The following is a description of a gene set: Absence of melanin pigment in various areas, which is found at birth and is permanent. The lesions are known as leucoderma and are often found on the face, trunk, or limbs. species: Homo sapiens Partial albinism Human Gene Set: HP_PARTIAL_ALBINISM, and this is the list of marker genes: MLPH, RAB27A, ZFX, KIT, MITF, MYO5A, PAX3, HPS6 (NCBI Gene Id 95477), LAMTOR2, TYRP1